Given this list of marker genes HIF1A, PLD1, ASAH2, CERS1, NFKB1, AKT1, MTOR, S1PR1, PIK3CA, SPHK2, IGF1R, TSC1 (TSC complex subunit 1), S1PR3, CERK, here is a description of the gene set: Human Gene Set: WP_MODULATION_OF_PI3KAKTMTOR_SIGNALING_BY_BIOACTIVE_SPHINGOLIPIDS studied in species Homo sapiens Modulation of PI3K-Akt-mTOR signaling by bioactive sphingolipids